Given this list of marker genes MEN1, BRAF, CTNNB1, AIP, CDH23, here is a description of the gene set: Sudden loss of visual acuity Human Gene Set: HP_SUDDEN_LOSS_OF_VISUAL_ACUITY Severe loss of visual acuity within hours or days. This is characteristic of Leber hereditary optic neuropathy. species: Homo sapiens